The following is a description of a gene set: species: Homo sapiens Human Gene Set: ACACTCC_MIR122A Genes having at least one occurence of the motif ACACTCC in their 3' untranslated region. The motif represents putative target (that is, seed match) of human mature miRNA hsa-miR-122a (v7.1 miRBase)., and this is the list of marker genes: SLC9A6, SLCO5A1, G3BP2, STK24, VAV3, SLC52A1 (solute carrier family 52 member 1), MARK1, RAD21, FAM219A, DLG2, MAF1, PTBP3, HNRNPU, GIT1, ANKRD13C, SERP1, LAMC1, H1-0, MECP2, TNPO3, SLC4A3, BACH2 (NCBI Gene Id 653980), BRWD1, BCAT2, CCDC6, SLC25A34, IQGAP1, P4HA1, TNRC6A, MMGT1, ZC2HC1C, CLIC4, DAND5 (DAN domain BMP antagonist family member 5), LRP10, CPEB1, ALDOA, PAK3, NTRK2, SMARCD1, SORCS1, NPEPPS, NEGR1, ORC2, GALC, CALM3, SLC39A8, ZDHHC7, MIPOL1, CDC42BPB, CCDC97, MSN, SLC52A2, MICU3, TBC1D10B, GYS1, CCNG1, HAND2, DICER1, PAPOLA, ADGRB2, BRPF1, MASP1, CD320, DLG4, ZNF827, RABL6, GTF3C2, CLIC5, CS, NFAT5, GNPDA2, FKBP5, OCLN, AGO1, MEIS2